Given this list of marker genes FBN1, PCSK5, NOL3, LRP5, TXNRD3, PLXNB1, FHIP1A, EDIL3, LRP6, STK39, LIMCH1, MN1, SELENOW, ICA1, ANGPTL2, LCA5, CDKN1C, SLC35D3, HS2ST1, here is a description of the gene set: studied in species Homo sapiens Genes up-regulated in non-neoplastic rectal mucosa samples from patients having cancer associated with ulcerative collitis, compared to those who did not have the cancer. PURPOSE: Ulcerative colitis (UC) is associated with a high risk of colorectal cancer. To identify genes that could predict the development of cancer in UC, we conducted a DNA microarray analysis using nonneoplastic rectal mucosa of UC patients. EXPERIMENTAL DESIGN: Gene expression in nonneoplastic mucosa of 53 UC patients were examined. Gene expression profiles were examined using human Genome U133 Plus 2.0 gene chip array (Affymetrix). Among 53 UC patients, 10 had UC-associated cancer (UC-Ca group) whereas 43 did not (UC-NonCa group). RESULTS: By comparing gene expression profiles of nonneoplastic rectal mucosae between the UC-Ca and UC-NonCa groups, we could identify genes that were differentially expressed between two groups. The list of discriminating genes included low-density lipoprotein receptor-related protein (LRP5 and LRP6). Previous studies suggested that LRP5 and LRP6 expression promotes cancer cell proliferation and tumorigenesis and are considered as candidate oncogenes. In the present study, both LRP5 and LRP6 showed significantly higher expression in the UC-Ca group, which suggests the importance of these genes in the development of UC-associated colorectal cancers. With the 40 selected discriminating genes, we did class prediction of the development of colorectal neoplasms in UC patients. Using the k-nearest neighbor method and the support vector machine, we could predict the development of UC-associated neoplasms with an accuracy of 86.8% and 98.1%, respectively. CONCLUSIONS: These findings have important implications for the early detection of malignant lesions in UC and may provide directions for future research into the molecular mechanisms of UC-associated cancer. Human Gene Set: WATANABE_ULCERATIVE_COLITIS_WITH_CANCER_UP from publication Watanabe T, Kobunai T, Toda E, Kanazawa T, Kazama Y, Tanaka J, Tanaka T, Yamamoto Y, Hata K, Kojima T, Yokoyama T, Konishi T, Okayama Y, Sugimoto Y, Oka T, Sasaki S, Ajioka Y, Muto T, Nagawa H (PMID 17255260)